The following is a description of a gene set: Human Gene Set: REACTOME_SIGNALING_BY_ERBB2_IN_CANCER species: Homo sapiens Signaling by ERBB2 in Cancer, and this is the list of marker genes: HSP90AA1, EREG, PIK3CA, PIK3R1, NRAS, GRB2, PTPN12, SOS1, KRAS (NCBI Gene Id 3845), BTC, EGFR, GAB1, HRAS, NRG1, HBEGF, PLCG1, ERBB3, SHC1, NRG2, ERBIN, NRG3, ERBB2, CDC37, ERBB4, NRG4, EGF